The following is a description of a gene set: species: Mus musculus Mouse Gene Set: REACTOME_REGULATION_OF_NF_KAPPA_B_SIGNALING Regulation of NF-kappa B signaling, and this is the list of marker genes: N4bp1, Chuk, Ikbkg, Traf2 (NCBI Gene Id 98924), Ikbkb, Ubb, Uba52, Casp8, Usp14, Uba52rt, Nlrx1, Ubc, Usp18, Rps27a, Nlrc5, Traf6, Lrrc14